Given this list of marker genes Ube2n, Ube2l3, Fbxw7, Fbxo5, Park7, Rpl11, Limk1, Trib3 (tribbles pseudokinase 3), Cdc20, Pin1rt1, Spry2, Pten, Rpl37rt, Htra2, Pin1, Ring1, Gcn1, Trib2, Rbck1, Rpl23, Otub1, Btrc (beta-transducin repeat containing protein), Glmn, Gbp4, Entrep1 (NCBI Gene Id 381217), Fzr1, Cdc20b, Trib1, Pcgf2, Rpl5, Rps7, Cdkn1b, Rps15, Pex12, Rpl37, Cbx8, Rps20, Bmi1 (NCBI Gene Id 12151), Cdkn2a, here is a description of the gene set: species: Mus musculus Binds to and modulates the activity of a ubiquitin-protein transferase, an enzyme that catalyzes the covalent attachment of ubiquitin to lysine in a substrate protein. Mouse Gene Set: GOMF_UBIQUITIN_PROTEIN_TRANSFERASE_REGULATOR_ACTIVITY